The following is a description of a gene set: Mouse Gene Set: DARWICHE_SQUAMOUS_CELL_CARCINOMA_DN Genes down-regulated in squamous cell carcinoma (SCC) compared to normal skin. studied in species Mus musculus from publication Darwiche N, Ryscavage A, Perez-Lorenzo R, Wright L, Bae DS, Hennings H, Yuspa SH, Glick AB (PMID 17525749) Chemical induction of squamous tumors in the mouse skin induces multiple benign papillomas: high-frequency terminally benign low-risk papillomas and low-frequency high-risk papillomas, the putative precursor lesions to squamous cell carcinoma (SCC). We have compared the gene expression profile of twenty different early low- and high-risk papillomas with normal skin and SCC. Unsupervised clustering of 514 differentially expressed genes (P<0.001) showed that 9/10 high-risk papillomas clustered with SCC, while 1/10 clustered with low-risk papillomas, and this correlated with keratin markers of tumor progression. Prediction analysis for microarrays (PAM) identified genes that distinguished the two papilloma classes, and a majority of these had a similar expression pattern in both high-risk papillomas and SCC. Additional classifier algorithms generated a gene list that correctly classified unknown benign tumors as low- or high-risk concordant with promotion protocol and keratin profiling. Reduced expression of immune function genes characterized the high-risk papillomas and SCC. Immunohistochemistry confirmed reduced T-cell number in high-risk papillomas, suggesting that reduced adaptive immunity defines papillomas that progress to SCC. These results demonstrate that murine premalignant lesions can be segregated into subgroups by gene expression patterns that correlate with risk for malignant conversion, and suggest a paradigm for generating diagnostic biomarkers for human premalignant lesions with unknown individual risk for malignant conversion., and this is the list of marker genes: Ambra1, Calcoco1, Map6, Acta2 (actin alpha 2, smooth muscle, aorta), Tcte1, Spata31d1e, Cox19, Lhx3, Smu1, Cspp1, Mycn, Tnp2, Vps37a, Ebf2 (NCBI Gene Id 13592), Kprp, Ccl27a, Poli (NCBI Gene Id 26447), 1700037C18Rik, Acta1, Tnfrsf25, Tpm3, Sfn, Map1lc3a, Eif5a, Scn1b, Swap70, Cp, Fam186a, Srsf1, Akirin2, Arhgap4, Tlcd3b (NCBI Gene Id 77785), H2-Q5, Ovol2, Zfp830, Gid8, Anp32a, Car3, Rspo1, Fam178b (family with sequence similarity 178, member B), Homer3, Raph1, Traf2, Trem2 (NCBI Gene Id 83433), Strap, Smkr-ps, Mef2c, Pacsin2, Ppp1r27, Ythdf2, Cct6b, Ttc9, Rpain, Lgmn, Rtn4r, 4930511M18Rik, Gstz1, Mapk8ip3, Aff3, Col20a1, Abhd14b, Fam3a, ENSMUSG00000122613, Sox5, Armc9, Bhlhe22, Asns, Hmbox1, Dip2a, Tuba8, Hamp, ENSMUSG00000136050, Akr1c18, Qprt, Irak1, Fbrsl1, Kcnu1, 6330403K07Rik, Tsc22d4, Mrpl19, Meox2, Art5, Acad9, Ltb4r1, Apoe, Cds1, Siglece, Inava, Sar1a, Ift20, Nbn, Nptxr, Tmem132cos, Gtf2e2, Mgat1, Med17, Pdp2, Cfap144, Rtraf, Racgap1, Otud1, Gnao1, Cpa5, Trpc6, Paqr7, Atp6v0d1 (NCBI Gene Id 11972), Slc39a13, Patj, Batf3, Ogfod2, Gba1, 2010203P06Rik, Dguok, Tssk6, Actg2, Calm4, Itpr1, Wdr70, Selenot, Tyro3, Gadd45gip1 (NCBI Gene Id 67697), Pygo2, Cx3cr1, Pex16, Nit1, Pvt1, 4930571K23Rik, Gtf2i, 1110004F10Rik, Foxl2, Ccni, Rnf26, Msi1, Brf1, Apod, Denr, Slc35b1, Srf, Clec3b, Eml4, Chchd5, Tex48 (NCBI Gene Id 75524), 4930529K09Rik, 4930556N13Rik, Lrif1, Lyar, Gabarapl2, Il17a, 3110070M22Rik, Ighg1, Il36a, 1700085D22Rik, Pus10, Pla2g10, Krtap6-5, Grip1, Coq8a, Ssu72, App, Pkhd1, Bag6, Pdxdc1, Brsk2, Fam217a, Nuf2, Zfp11, Dok4, Cenpc1, 4933406D12Rik, Ankef1, Tmem144, Lrrc58, Dynlt2b, Bcl2a1d, Calm2, Bbln, Myo1a, Pabpc4, Chst11, Actl6b, 1700123O20Rik, Smim11, Rps3a1, Phf2, Spanxn4, Prrc1, Ptprjos1, Spag5, Zfp787, Lmod2, Serpinb3c, Ube4b, Pepd, Krt2, Krtap5-4, Spc24, Dctn1, Lgals2 (NCBI Gene Id 66535), Rbm12, Trbv5